The following is a description of a gene set: Human Gene Set: HP_ABNORMAL_BRANCHING_PATTERN_OF_THE_AORTIC_ARCH A deviance from the norm of the origin or course of the right brachiocephalic artery, the left common carotid artery, the left subclavian artery or the proximal vertebral arteries. Abnormal branching pattern of the aortic arch studied in species Homo sapiens, and this is the list of marker genes: FLT4, DGCR8, WT1, NKX2-6, CFAP53, DNAH9, DGCR2, PLXND1, PLD1, ESS2, IPO8, TMEM260, PIK3R2, STRA6, MMP21, DGCR6, TBCK, GDF1, CREBBP, TELO2, SF3B2, CRELD1, IFT56, ACVR2B, CIROP, WDR26, PKD1L1 (polycystin 1 like 1, transient receptor potential channel interacting), CLXN, EP300, DNAH1, GBA1, ZMYM3, TBX1, CHD7